Given this list of marker genes SRPRB, FOXD1, PER2, CCDC89, MGAM, NFIX, ZNF117, PDP1, TMEM154, PHF8, DPP10, RAB7A, TBK1, SUPT20H, HIPK3, LRP4, NR2C1, UPP1, COL19A1, LRRFIP1, TLK1, CYP2C18, LUZP4, ITGBL1, CYREN, POLR1F, ZFP90, SMIM13, RORA, TNFSF10, FOXO1, ZNF708, TUBB1, NIPAL1, NCAN, CACNA1D, MAP4K4, DMRT3, ZNF559, UBP1, NSUN7, TUB, PLAAT3, PLEKHM3, CTSO, GLCE, KCNC1, TIGAR, FAM124B, CCDC90B, ZNF138, PIWIL1, SLC17A1, TRMT13, PDRG1, ZC2HC1A, SHB, PCGF2 (polycomb group ring finger 2), SMAD7, CIMAP1A, DMAC1, DEFB110, OVGP1, LIN28A, NALCN, ALDH6A1, PDXDC1, JADE1, ZBTB10, HAUS2, LRRTM4, EMC3, DICER1, LY9, RBM15, CLDND1, SPON1, BPNT2, HNRNPU, QRSL1, METTL15, here is a description of the gene set: Genes predicted to be targets of miRBase v22 microRNA hsa-miR-581 in miRDB v6.0 with MirTarget v4 prediction scores > 80 (high confidence targets). studied in species Homo sapiens from publication Chen Y, Wang X (PMID 31504780) Human Gene Set: MIR581